Given this list of marker genes KRT6B, KRT17, KRT16, PLEC, KRT6A, KRT1, PKP1, KRT14, KRT5, COL7A1, DSG1, here is a description of the gene set: A type of blistering that affects the skin of the palms of the hands and the soles of the feet. Palmoplantar blistering species: Homo sapiens Human Gene Set: HP_PALMOPLANTAR_BLISTERING